Given this list of marker genes Trappc3, Prl2a1, Pbx3, Mb (NCBI Gene Id 223670), Szrd1, D930020B18Rik, Acsm1, Ephb2, Zfp697, P2rx2, Rims2, Hspb6, Cdkn1a, Lhpp, Cdh2, Fgr, Esp36, Ppef1 (protein phosphatase with EF hand calcium-binding domain 1), Slc25a23, Clip3, Msr1, Ebf4, Crnkl1, Mdh1b, Itpripl2, Nfs1, Cdipt, Spred3, Anapc1, Wiz, Aph1a, Penk, Prom2, Dlk1, Ets1, Nherf2, Tfap4, Gbp10, Gramd1a, Ptpn4, Fgf23, Wnk1 (NCBI Gene Id 406236), Zcchc3, Mgrn1, Adamts20, Setdb1, here is a description of the gene set: from publication Chen Y, Wang X (PMID 31504780) studied in species Mus musculus Mouse Gene Set: MIR_7009_5P Genes predicted to be targets of miRBase v22 microRNA mmu_miR_7009_5p in miRDB v6.0 with MirTarget v4 prediction scores > 80 (high confidence targets).